The following is a description of a gene set: Human Gene Set: DESCARTES_MAIN_FETAL_MEGAKARYOCYTES Marker genes curated from the annotated cluster as represented in the Descartes Human Gene Expression During Development database. The gene expression program underlying the specification of human cell types is of fundamental interest. The study authors generated human cell atlases of gene expression and chromatin accessibility in fetal tissues. For gene expression, the study authors applied three-level combinatorial indexing to >110 samples representing 15 organs, ultimately profiling ~4 million single cells. The study authors leveraged the literature and other atlases to identify and annotate hundreds of cell types and subtypes, both within and across tissues. Our analyses focused on organ-specific specializations of broadly distributed cell types (such as blood, endothelial, and epithelial), sites of fetal erythropoiesis (which notably included the adrenal gland), and integration with mouse developmental atlases (such as conserved specification of blood cells). These data represent a rich resource for the exploration of in vivo human gene expression in diverse tissues and cell types. species: Homo sapiens from publication Cao J, O'Day DR, Pliner HA, Kingsley PD, Deng M, Daza RM, Zager MA, Aldinger KA, Blecher-Gonen R, Zhang F, Spielmann M, Palis J, Doherty D, Steemers FJ, Glass IA, Trapnell C, Shendure J (PMID 33184181), and this is the list of marker genes: LAT, PSTPIP2, PARVB, LINC00534, RASGRP2 (RAS guanyl releasing protein 2), PKN2-AS1, EGF, GOT2P7, GP9, CMTM2, CMTM5, SRC, C11orf21, C5orf58, INPP4B, PRKAR2B-AS1, KIF2A, PIRAT1, SLC24A3, STXBP5, VCL, FHOD1, SAMD14, NRGN, PTGS1, LY6G6F (lymphocyte antigen 6 family member G6F), CDKN2D, TGFB1, ABHD16A, PRKAR2B, TSPOAP1-AS1, MFAP3L, CAPN1-AS1, RELCH, NOL4L, BMS1P10, MCTP1, SUSD3, UPK1A-AS1, ZNF175, DNM1L, NRDC, DOK1, ACRBP, DOK3, THUMPD2, ENSG00000250348, LINC00642, TMEM91, GAS2L1, GP6 (glycoprotein VI platelet), CGRRF1, GCSAML, ASAP2, AXIN1, TPSAB1, INHBA-AS1, ILK, RUFY1, SLC2A3, ABCC4, LINC02752, ATP2A3, SLC39A3, P2RX1, TUBA8, PF4V1, ENSG00000258803, TREML1, UNC13D, PIGB, BLZF2P (basic leucine zipper nuclear factor 2, pseudogene), ENSG00000254006, GFI1B, CAPN11, L3MBTL2-AS1, COL24A1, BANK1, LINC00989, LIMS1, ALOX12, TBX10, MPIG6B, PLEK, UBE2C, RAB8A, LINC03044, THBS1, SLC30A5, MICU1 (NCBI Gene Id 51415), MAFG, TBXA2R, BTK, NT5C3A, NAT8B, GPX1, KCNK6, DCLRE1A, LRP12, CNST, XRCC2, DIAPH1, LY6G6E, ACTN1, MAPK6P5, FCER1A, ZYX, RPL21P13, IRAG1, PCYOX1L, THOC2, LYL1, ARHGAP6, CTTN, CD226, SLC37A1, NT5M, LY6G6F-LY6G6D, GP5, NXF3, F2RL3, DGKG, GNB5, FLI1, RASA3, SEC14L5, GSAP, ELOVL7, HBD, RGS18, MEIS3P2, MYH9-DT, NBEAL2 (NCBI Gene Id 23218), BEND2, RPL21P11, MPL, AKR1C5P, PADI4, TPST2, SMIM12, PROSER2, DGKD, GP1BA, TAOK1, P2RY1, NEXN-AS1, LINC00504, STXBP2, RPS29P14, FAM30A, TUBB1, LINC02770, TLN1, RAB27B, LGALSL, FERMT3 (FERM domain containing kindlin 3), BIN2, ITGB3, ENSG00000245008, MAX, TTC27, TSPAN32, MYH9 (NCBI Gene Id 65212), TEC, PHKB, ROCK2, ATP2C1, SWINGN, INAFM2, LRRFIP2, RAP2B, ACTN1-DT, RSU1, INKA1, HTR2A, CLEC1B, LTBP1, ENSG00000227355, TTC7B, SETP11, FAM110A (family with sequence similarity 110 member A), LINC02694, TPSB2, SLC18A2-AS1, HPSE, VASP, ITGA2B, ING5, LINC02284, GFOD1, PDE5A, EFCAB13-DT, LINC01565, KIAA0513, CENPT, RAB37 (RAB37, member RAS oncogene family), PF4, YIF1B, PRUNE1, AQP10, MDM1, TUBA4A, LGALS12 (galectin 12), PROS1, CATSPER1, RAP1B, CPA3, ADCY6, PPBP, SIAE, SELP, LINC02915, SUSD1